Given this list of marker genes H2AZ2, H2AC6, H3C2, H3C3, H2AC14, H4C11, H2BC3, AR, H3C8, H2BC11, H3-3B, H4C16, H2BC5, H2BC13, H3C12, H3C15, H2AC19, H2BC21, H2BC15, H4C12, NCOA2, H3C10, H2AB1, H2BC12L, H3C6, H4C4, H2BC7, H4C3, H2BC6, H3C14, H2BC26, H4C15, H3C4 (H3 clustered histone 4), H4C13, H3C11, H2BC9, H4C5, H2BC17, H3-3A, H3C1, KLK3, H4C8, H4C9, H2AC20, H3C7, H2AC4, H2AC8, H2BC10, H4C2, H2BC1, H4C14, KLK2, H2AX, KDM4C, H3C13, H2AJ, KDM1A, PKN1, H2AC18, H4C6, H2BC12, H2AC7, H2BC4, H4C1, H2BC8, H2BC14, here is a description of the gene set: Human Gene Set: REACTOME_ACTIVATED_PKN1_STIMULATES_TRANSCRIPTION_OF_AR_ANDROGEN_RECEPTOR_REGULATED_GENES_KLK2_AND_KLK3 Activated PKN1 stimulates transcription of AR (androgen receptor) regulated genes KLK2 and KLK3 studied in species Homo sapiens